Given this list of marker genes ADAR, POU2AF1, IFNL1, PENK, TGFB1, PYDC5, TRIM6, CXCL10, EIF5A, HSP90AA1, IFNL4, IFIH1, IFNA2, MMP12, DDX3X, OAS1, IFNA17, GSDME (gasdermin E), BAX, IFNB1, TLR3, GLI2, IL12A, IFNA10, IFNA6, CHUK, ARF1, LGALS9 (NCBI Gene Id 90793), IFNA5, IFNA4, MIR146A, GBF1, IFNG, IFNGR2, MAPK14, IFNA16, CCL5, IFNGR1, IFNAR2, JAK2, ZC3H12A, IFNA7, MIR21, WDFY4, HIF1A, LGALS8 (NCBI Gene Id 3964), MIR29B1, POU2F2, EXT1, MIR30C1 (microRNA 30c-1), MAPK11, MIR302A (NCBI Gene Id 407028), IFNW1, IFNA14, TOMM70, RRP1B, IFI6, MIR130A, SMAD3, NLRP3, IFNA8, TLR7, FMR1, IFNLR1, IFNL3, IRF5, ATF2, IFNE, IL6, IFNL2, IL10RB, IRGM, IFNA1, MIR758, IFNA21 (interferon alpha 21), MIR675, CCL19, IFNK, IFI44, CALR, RIOK3, NFKB1, VWCE, JAK1, TYK2, IL21, IFNAR1, IRF3, IKBKE, here is a description of the gene set: Human Gene Set: GOBP_CELLULAR_RESPONSE_TO_VIRUS species: Homo sapiens Any process that results in a change in state or activity of a cell (in terms of movement, secretion, enzyme production, gene expression, etc.) as a result of a stimulus from a virus.